Given this list of marker genes Ubb, Rps27a, Ngly1, Rad23b, Vcp, Calr, Uba52, Ubc, Uba52rt, Derl1, Ubxn1, Pdia3, Canx (NCBI Gene Id 66219), Amfr, Engase, Psmc1, here is a description of the gene set: N-glycan trimming in the ER and Calnexin/Calreticulin cycle studied in species Mus musculus Mouse Gene Set: REACTOME_N_GLYCAN_TRIMMING_IN_THE_ER_AND_CALNEXIN_CALRETICULIN_CYCLE